Given this list of marker genes CYP51A1, AHR, CYP7B1, CYP7A1, ARNT2, NR1H4, CYP4V2, CYP11B2, POMC, NCOA2, CYP11B1, CYP19A1, CYP21A2, RXRA, CYP39A1, FDX2, FDXR, NCOA1, CYP46A1, CYP8B1, CYP11A1, ARNT, CYP1B1, CYP27A1, FDX1, here is a description of the gene set: Endogenous sterols species: Homo sapiens Human Gene Set: REACTOME_ENDOGENOUS_STEROLS